Given this list of marker genes DERL1, RAC1, CST3, BID, SLC1A2, MAP2K2, BCL2, CASP1, BAX, GPX1, PPP3CA, MAP2K6, DAXX, CAT, BCL2L1, BAD, TNF, PPP3CC, TP53, PPP3CB, APAF1, PRPH (NCBI Gene Id 5630), MAPK14, GRIA1, TNFRSF1A, CASP3, TOMM40, RAB5A, ALS2, NEFM, NEFH, NEFL, CCS, SOD1 (superoxide dismutase 1), CASP9, MAP3K5, SMIM40, NOS1, here is a description of the gene set: Amyotrophic lateral sclerosis (ALS) species: Homo sapiens Human Gene Set: WP_AMYOTROPHIC_LATERAL_SCLEROSIS_ALS